The following is a description of a gene set: Mouse Gene Set: GOBP_REGULATION_OF_ANIMAL_ORGAN_FORMATION Any process that modulates the rate, frequency or extent of animal organ formation. Organ formation is the process pertaining to the initial formation of an organ from unspecified parts. The process begins with the specific processes that contribute to the appearance of the discrete structure, such as inductive events, and ends when the structural rudiment of the organ is recognizable, such as a condensation of mesenchymal cells into the organ rudiment. species: Mus musculus, and this is the list of marker genes: Cited2, Sulf1, Fgfr1, Fgf3, Hoxd11 (NCBI Gene Id 319663), Wnt5a (wingless-type MMTV integration site family, member 5A), Robo1, Shh, Ctnnb1, Fgf10, Bmp4, Bmp2, Rbpj, Gdnf, Hoxa11, Fgf8, Robo2, Six1, Bmp7, Gata5, Wt1, Wnt2, Frs2, Fgfr4, Fgf1, Mesp1 (mesoderm posterior 1), Spry1, Wnt2b, Dkk1, Fgf2, Ar, Hoxc11